The following is a description of a gene set: Short lingual frenulum Human Gene Set: HP_SHORT_LINGUAL_FRENULUM studied in species Homo sapiens The presence of an abnormally short lingual frenulum., and this is the list of marker genes: WDR35, ATP6V1B2, FREM1, ZMPSTE24, DVL1, LMNA, WNT5A, B3GLCT, KIAA0753, SMARCA2, CDK13, TBC1D24